The following is a description of a gene set: part of: ER to Golgi Anterograde Transport Reactome Pathway: COPI-mediated anterograde transport species: Homo sapiens The ERGIC (ER-to-Golgi intermediate compartment, also known as vesicular-tubular clusters, VTCs) is a stable, biochemically distinct compartment located adjacent to ER exit sites. The ERGIC concentrates COPII-derived cargo from the ER for further anterograde transport to the cis-Golgi and also recycles resident ER proteins back to the ER through retrograde traffic. Both of these pathways appear to make use of microtubule-directed COPI-coated vesicles., and this is the list of marker genes: TMED7, RAB1B, INS, COPB1, COG4 (component of oligomeric golgi complex 4), COPZ2, CAPZA3, DCTN6, STX5, NSF, FOLR1, COG1, GORASP1 (golgi reassembly stacking protein 1), ARF1, BET1L, DYNC1I2 (NCBI Gene Id 1781), TUBB8, COPZ1, TUBB1, COG6, TUBAL3, ARF3, ARF5, TMED3, COPE, ARFGAP1, SPTB, SPTBN5 (NCBI Gene Id 51332), TUBA1C, BET1, TUBB6, KDELR2, GBF1, RAB1A, COPG2 (NCBI Gene Id 80038), KDELR1, ANK3 (NCBI Gene Id 288), TUBA8, COG2, TUBA4A, TUBB2B, TUBB4A, TMED10, CAPZA2, DCTN5, DYNC1LI1, ACTR10, GOSR1, DYNC1I1, NAPB, USO1, GOSR2, CAPZA1, DCTN2, DCTN4, ARFGAP3, NAPG, TMED2, TUBA1B, DYNC1LI2, TUBB2A (NCBI Gene Id 92919), COG3, TUBB8B, TMED9, GOLGA2, SPTA1, TUBA1A, COG5, TMEM115, COG7, TUBA3D, CAPZB, GOLGB1, ARFGAP2, COPB2, CD59, SPTBN2, COPA, ACTR1A, ARCN1, TUBB4B, SPTBN4, COPG1, DYNLL2, ANK1, ARF4, KDELR3, SPTAN1, TUBA3E, DCTN3, ANK2, SPTBN1, DYNLL1, COG8, DCTN1, TUBA3C, TUBB3, CD55, DYNC1H1, NAPA, TUBA4B, YKT6